The following is a description of a gene set: COPII-mediated vesicle transport Human Gene Set: REACTOME_COPII_MEDIATED_VESICLE_TRANSPORT species: Homo sapiens, and this is the list of marker genes: NAPA, CNIH2, BET1, SEC31B, SEC16A, SEC22A, TRAPPC6A, STX17, SEC13 (NCBI Gene Id 6396), SCFD1 (NCBI Gene Id 51681), AREG, SEC22B, STX5, TMED10, MCFD2, USO1, SEC24C, LMAN2, TRAPPC10, GOLGA2, CD59, SEC24D, NSF, TRAPPC1, LMAN1, PPP6C, CNIH3, CTSC, RAB1A, TRAPPC3, PREB, PPP6R1, TRAPPC5, TRAPPC4, F8, COL7A1, TGFA, TRAPPC6B, CSNK1D (casein kinase 1 delta), SEC31A, SEC23IP, SEC24A, RAB1B, TBC1D20, TRAPPC2, SEC16B, SEC22C, LMAN2L, TFG, CTSZ, F5, FOLR1, GOSR2, TRAPPC9, YKT6, CNIH1, LMAN1L, TMED2, ANKRD28, GORASP1, PPP6R3, NAPG, SEC24B, SERPINA1, GRIA1, NAPB, TRAPPC2L, SAR1B, SEC23A